The following is a description of a gene set: Mouse Gene Set: GOBP_MALATE_ASPARTATE_SHUTTLE The process of transferring reducing equivalents from NADH in the cytosol to the mitochondria via malate. Cytosolic aspartate aminotransferase converts aspartate to oxaloacetate, and cytosolic malate dehydrogenase uses NADH to convert oxaloacetate to malate in the cytosol; the malate-alpha-ketoglutarate carrier then transports the malate into the mitochondria where mitochondrial malate dehydrogenase uses NAD to convert malate back to oxaloacetate; the electrons on the reduced NADH are then available for use in the electron transport chain; mitochondrial aspartate aminotransferase converts oxaloacetate to aspartate, and the glutamate-aspartate carrier transports the aspartate back to the cytosol to complete the cycle. studied in species Mus musculus, and this is the list of marker genes: Slc25a22, Slc25a13, Got2, Slc25a12, Got1, Slc1a3, Mdh2, Slc25a11, Mdh1, Slc25a18